The following is a description of a gene set: Mouse Gene Set: GOBP_CHEMOKINE_C_C_MOTIF_LIGAND_5_PRODUCTION species: Mus musculus The appearance of chemokine (C-C motif) ligand 5 due to biosynthesis or secretion following a cellular stimulus, resulting in an increase in its intracellular or extracellular levels., and this is the list of marker genes: Oas3, Ticam2, Defb25, Trpv4, Arg2, Mavs, Sirpa, Adcyap1, Mcoln2, Mul1, Tusc2